Given this list of marker genes GUCD1, FIRRM, FPR2, MAP3K10, MED28, GINS1, HIBADH, CNEP1R1, SLC9B2, CSRP1 (NCBI Gene Id 1465), DUSP1, MRPL49, GOLGA7, SGPP2, PPP1CC, ACAA2, TCTA, LIPA, TMEM60, COPS4, ARFIP1, RABGAP1L, FAM13B, LY6D, RNF166, SLC22A3, PTMS, MINDY1, CCDC71, CIC, ATG16L1, MIR22HG, VAPB, MRPL50, MAP1LC3B, EMC3, SLPI, FUT11, WAC, ZNF212, TTLL6, INSIG1, CLK4, PEX2, CELF6, RNASEH2A, MON1A, FEN1, NET1, MVD, NDUFV2, UNG, CFAP20DC, CD8B, APIP, ATP6AP1, GCHFR, HIKESHI, RP2, NAXE, TMEM127, UBA3, ELL3, METTL26, ATP6V1G1, IRAK2, RNF168, PPP2R5C, MPV17L2, STX6, MRNIP, PSMB10, GPSM2, TMEM160, PCDHB5, CBX2, OLFML1, CD2, CHIC2, PRCP, WDR7, MFF, CD99, SELENOO, ELF2, TMEM229A, CNOT8, CGGBP1, TMEM179B, MYOT, PHF24, SIRT7, FBXL5, PDCD1, ACTRT3, HIPK1, ADAMTS19, ENC1, C14orf119, UBALD2, IFT27, BFAR, TRIR, CAMK2G, NCALD, FLOT1, PNISR, CIAO1 (cytosolic iron-sulfur assembly component 1), C6orf132, NID1, CEP19, BCL2L15, RBM7, MDM1, IKBIP, DDX19A, DUSP6, TRAF7, GSTM3, MSMO1, PRM2, STAT4, CCDC162P, SMYD4, SUCLG1, NDUFB10 (NADH:ubiquinone oxidoreductase subunit B10), MN1 (MN1 proto-oncogene, transcriptional regulator), MKRN3, COPZ1, EHBP1 (EH domain binding protein 1), GALE, KLC3, MED30, FXN, ADAMTS2, LTA4H, TMEM183A, CCDC150, PTS, PLGRKT, MBD4, KCNMB4 (NCBI Gene Id 27345), HAT1, DOK2, FGB, NLK, DSCAM, SHROOM4 (NCBI Gene Id 57477), SAMSN1, PARP6, RHOG, FLOT2, FBXO25, ENDOD1, FAM89B, DPM2, UBR7, VAMP4, TMEM199, CLIC1, APOC3, SEPTIN1, MRPS12, NPAS1, HSD17B3, KDSR, RPAIN, OSBPL9, PRKRA, IGBP1, MRPS25, COMMD7, TMEM18, ALDH7A1, PAIP2, MPPE1, CYP51A1, ZDHHC16, GABARAPL1, SGSM3, IL1R2, NRBF2, ELOF1, GPN2, ATPSCKMT, RBM48 (NCBI Gene Id 84849), ERI1, PXMP2, SAV1 (salvador family WW domain containing protein 1), HSD11B1, STAG1, CIP2A, BTG3, SUMF1, GEM, ST3GAL2, ZMYM5, RPS27, SDF4, CYLD, here is a description of the gene set: Genes up-regulated in neutrophils treated with CSF2 versus control. studied in species Homo sapiens from publication Daryadel A, Yousefi S, Troi D, Schmid I, Schmidt-Mende J, Mordasini C, Dahinden CA, Ziemiecki A, Simon HU (PMID 19414807) The objective of this study was to compare the transcriptional repertoire of mature human neutrophils before and after GM-CSF treatment by using oligonucleotide microarrays. Leukotriene B4 (LTB4) is an important pro-inflammatory lipid mediator generated by neutrophils upon activation. Granulocyte/macrophage colony-stimulating factor (GM-CSF) stimulation is known to enhance agonist-mediated LTB4 production of neutrophils within minutes, a process called “priming”. Here, we demonstrate that GM-CSF also limits the production of LTB4 by neutrophils via a transcriptional mechanism at later time points. We identified hematopoietic specific Ras homologous (RhoH)/translocation three four (TTF), which was induced following GM-CSF stimulation in neutrophils, as a key regulator in this process. Neutrophils derived from RhoH/TTF-deficient (Rhoh-/-) mice demonstrated increased LTB4 production upon activation compared with normal mouse neutrophils. Moreover, neutrophils from cystic fibrosis patients expressed enhanced levels of RhoH/TTF and generated less LTB4 upon activation compared with normal human neutrophils. Taken together, these data suggest that RhoH/TTF represents an inducible feedback inhibitor in neutrophils that is involved in the limitation of innate immune responses. Human Gene Set: GSE15139_GMCSF_TREATED_VS_UNTREATED_NEUTROPHILS_UP